Given this list of marker genes Slc20a1, Slc37a2, Slc25a10, Slc37a4, Xpr1, Vdr, Slc17a1, Slc25a3, Slc20a2, Slc37a1, Ank, Slc17a7, Slc34a1, here is a description of the gene set: The process in which a phosphate is transported across a membrane. Mouse Gene Set: GOBP_PHOSPHATE_ION_TRANSMEMBRANE_TRANSPORT studied in species Mus musculus